Given this list of marker genes PGRMC1, MIR148A, MIR128-1, TMEM97, APOE, here is a description of the gene set: studied in species Homo sapiens Human Gene Set: GOBP_REGULATION_OF_LIPOPROTEIN_TRANSPORT Any process that controls lipoprotein transport.